Given this list of marker genes KRT5, EPHA1, HLA-DQA1, H2BC7 (NCBI Gene Id 8343), CDYL, SERPINB8, UBXN2B, SYNPO, EPAS1, ENKUR, PAPPA, IRF8, HLA-DOA, TBC1D8, WNT9A, DLK1, NRN1, ZC3H12B, HMGN5, MECOM, MAP3K7CL, ANGPT1, PLCH1, NOMO1, P2RY12, KCNAB1, PID1, TNS1 (tensin 1), CA8, FCER1A, FLNB, DPYSL3, KCTD12, ATP13A5, MFAP3L, RPH3AL, GRHL1, AGBL3, DNAH12, DPYD, TFPI2 (tissue factor pathway inhibitor 2), ZNF347, PDCD1LG2, RAMP3, ANKRD33B, IGF2, REG1B, PAPSS2, TRAM1, ARHGAP29, TGFBI, AFF2, CYP11A1, CYCS, GPR55, CTNND2, SIGLEC12, PRIMPOL, SEPTIN7, RGS18, CLIC5, ALDH1A1, LILRA1, VEGFA, UTRN, POC1B, ZNF438, CADM2, PF4V1, ITGB3BP, FAM241A, BEND2, ZNF660, WWOX, IL7R, AVPR1A, RPA1, DCDC2, KRTAP29-1, GPIHBP1 (NCBI Gene Id 338328), CALU, SH2D1A, HLA-DQB1, LYSMD3, SMAD5 (NCBI Gene Id 4090), A2M, CEP128 (centrosomal protein 128), PPM1E, CXCL12, MS4A7, P2RY14, SNAP25, SDK1, CAVIN1, ZNF490, TMEM150C, DAB2IP, GASK1B, HAT1, COL4A2, DYTN, IDS, HEMGN (NCBI Gene Id 55363), GARIN1B, PTPRD, CAVIN2, ENSG00000285976, EMCN, CXCL6, SETD7, COA1, BANK1, LOXHD1, ACKR2, COL4A1, LEPR, MINAR1, CPNE4, PABIR2, MAPK10, CD4, CA2, NXT2, AFF3, NCOA4, TAS2R14, RLN1, MLH3, FAM107B, GLRA4, GLYATL2, CEMIP, ANKRD55, APCDD1L, LGALS2, SPIB, VWA8, ENTHD1, ARPIN, MAGOHB, IRX3, RANBP17, RNASE3, ANXA3, ADAM12, PHEX, CXCL5, PLCL1, CA5A, GNG10 (NCBI Gene Id 2790), PARD3B, BTLA, PSRC1, OR11L1, TMEM70, NAP1L3, LRRCC1, ACADM, LIMS3, ENAH, FGD5, POLR3G (NCBI Gene Id 10622), STK26, HLA-DRA, ATP13A4, LDB2, TGFB2, ADORA2A, SLC18A3, ERC2, OPA1, EFNA5 (ephrin A5), SH3BGRL, RNF212B, ZNRF2, SCIN, CFAP97D1, WDFY4, LIG4, PDE6H, FANCA, ZNF117 (zinc finger protein 117), BPIFB3, P2RY10, TBX3, PLD4, HSD17B3, TPPP3, COL25A1 (NCBI Gene Id 84570), SPC25, WLS, YAP1, SLC4A8, RNF11, ZNF367, ZNF726, ENTREP2 (NCBI Gene Id 23359), CPPED1, CCDC50, CD1C, PHACTR3, KDR, MSANTD3-TMEFF1, FTO, ANKDD1B, DMD, GPR88, here is a description of the gene set: from publication Manne BK, Denorme F, Middleton EA, Portier I, Rowley JW, Stubben C, Petrey AC, Tolley ND, Guo L, Cody M, Weyrich AS, Yost CC, Rondina MT, Campbell RA (PMID 32573711) studied in species Homo sapiens Strongly downregulated genes from differential gene expression analysis of platelets from 6 Non-ICU patients with SARS-CoV-2 infection as well as 5 healthy donors. Human Gene Set: MANNE_COVID19_NONICU_VS_HEALTHY_DONOR_PLATELETS_DN Thrombotic complications in patients with COVID-19 are common and contribute to organ failure and mortality. Patients with severe COVID-19 present with hemostatic abnormalities that mimic disseminated intravascular coagulopathy associated with sepsis with the major difference being increased risk of thrombosis rather than bleeding. However, whether SARS-CoV-2 infection alters platelet function to contribute to the pathophysiology of COVID-19 remains unknown. In this study, we report altered platelet gene expression and functional responses in patients infected with SARS-CoV-2.